The following is a description of a gene set: Mouse Gene Set: GOCC_CENTRAL_REGION_OF_GROWTH_CONE studied in species Mus musculus The center of the migrating motile tip of a growing nerve cell axon or dendrite., and this is the list of marker genes: Disc1, Kif5a, Ywhae, Ndel1, Adcy10, Cyfip1, Pafah1b1